The following is a description of a gene set: Human Gene Set: BROWNE_HCMV_INFECTION_10HR_DN from publication Browne EP, Wing B, Coleman D, Shenk T (PMID 11711622) The effect of human cytomegalovirus (HCMV) infection on cellular mRNA accumulation was analyzed by gene chip technology. During a 48-h time course after infection of human diploid fibroblasts, 1,425 cellular mRNAs were found to be up-regulated or down-regulated by threefold or greater in at least two consecutive time points. Several classes of genes were prominently affected, including interferon response genes, cell cycle regulators, apoptosis regulators, inflammatory pathway genes, and immune regulators. The number of mRNAs that were up-regulated or down-regulated were roughly equal over the complete time course. However, for the first 8 h after infection, the number of up-regulated mRNAs was significantly less than the number of down-regulated mRNAs. By analyzing the mRNA expression profile of cells infected in the presence of cycloheximide, it was found that a minimum of 25 mRNAs were modulated by HCMV in the absence of protein synthesis. These included mRNAs encoded by a small number of interferon-responsive genes, as well as beta interferon itself. Cellular mRNA levels in cytomegalovirus-infected cells were compared to the levels in cells infected with UV-inactivated virus. The inactivated virus caused the up-regulation of a much greater number of mRNAs, many of which encoded proteins with antiviral roles, such as interferon-responsive genes and proinflammatory cytokines. These data argue that one or more newly synthesized viral gene products block the induction of antiviral pathways that are triggered by HCMV binding and entry. Genes down-regulated in primary fibroblast cell culture after infection with HCMV (AD169 strain) at 10 h time point that were not down-regulated at the previous time point, 8 h. species: Homo sapiens, and this is the list of marker genes: CBLB, PTGFR, ZNF23, RBMS1, IFT70A, BLK, SLC5A4, IGF2BP3, IRS1, PNN, SETX, MGA, PNOC, METTL13, PRKY, B2M, ARHGAP29, KLF9, GLOD4, NT5E, DENND2B, MTUS1, KIF11, ENSG00000291006, RGS20, HOXA11, ETV1, TCF7L2, NR3C1, ANKRD28, RANBP6 (RAN binding protein 6), EMP1, RHOBTB1, PCF11, AHR (aryl hydrocarbon receptor), EEF1A1, STAMBP, ZSCAN26, NIPBL, PARP4, GEMIN2 (gem nuclear organelle associated protein 2), NUP42, SON, BDNF, RDH11, RAD17, AIMP2, NDUFB7, RIN2, AMACR, ANP32A, RUNX1, FRY, OGG1, ADORA2B, FBXL2, SCN8A